Given this list of marker genes CALCRL, GRM1, RAMP2, GABBR1, GPR156 (G protein-coupled receptor 156), RAMP3, GABBR2 (NCBI Gene Id 9568), here is a description of the gene set: Human Gene Set: GOCC_G_PROTEIN_COUPLED_RECEPTOR_DIMERIC_COMPLEX species: Homo sapiens A protein complex that contains two G protein-coupled receptors.